The following is a description of a gene set: Any process that modulates the frequency, rate or extent of osteoblast proliferation. species: Homo sapiens Human Gene Set: GOBP_REGULATION_OF_OSTEOBLAST_PROLIFERATION, and this is the list of marker genes: EIF2AK2, SMAD3, MIR9-1, GATA1, AXIN2, FBLN5, SOX8, CCN1, LRP5, MN1, HPSE, ITGAV, ABL1, CTHRC1, SFRP1, MIR675, MIR138-1, ATRAID, NELL1, FGFR2, TMEM119, BMP2, RHOA, NF2, GREM1, BCL2, ITGB3, NPR3, LTF, PLXNB1